Given this list of marker genes BMP6, NBL1, GREM1, BMP2, BMP8A, GDF6, BMP8B, GDF7, GDF5, BMP4, BMP5, GREM2, NOG, CHRD, BMP7, here is a description of the gene set: Pathway Definition from KEGG: (NOG,GREM,CHRD,NBL1) -| BMP Human Gene Set: KEGG_MEDICUS_REFERENCE_BMP_SIGNALING_PATHWAY_BMP_ANTAGONIST studied in species Homo sapiens BMP signaling pathway, BMP antagonist. Pathway ID: N01428. Pathway type: Reference. Pathway class: nt06507 TGFB signaling.